Given this list of marker genes INSR, TBC1D4, MTOR, AKT2, IRS1, RPS6KB1, SLC2A4, RPS6, here is a description of the gene set: Human Gene Set: WP_INSULIN_SIGNALING_IN_ADIPOCYTES_NORMAL_CONDITION Insulin signaling in adipocytes (normal condition) species: Homo sapiens